The following is a description of a gene set: from publication Chen Y, Wang X (PMID 31504780) Human Gene Set: MIR6719_3P species: Homo sapiens Genes predicted to be targets of miRBase v22 microRNA hsa-miR-6719-3p in miRDB v6.0 with MirTarget v4 prediction scores > 80 (high confidence targets)., and this is the list of marker genes: BHLHE22, NAB1, SH3RF3, SULT1C4, MAP3K2, GRIA2, MRPS10, ANTXR2, NAMPT, VANGL1, MAP3K20, PPP2CA, SLC35A3, SELE, PAPOLB, NKRF, RICTOR, AFAP1L1, SCOC, SUSD6, RIF1, MGA, WDR7, SENP6, TMX4, ZNF75D, XPNPEP3, OTUD6B, TTK, MICU2, TBCEL, HOXC8, ARRB1, VTI1A, NR3C1, TTF1, GPR26, SLC19A2, ZNF286A, BRD3, ENPP5, WDR36, RTL8A, DENND4A, ERCC8, LINC02914, ZNF286B, ING2, FNIP1 (NCBI Gene Id 96459), NHS, DCLK3, CUL3, PSPH, MICAL2, ZNF268, SLC6A11, SLC12A3, CCDC88A, KDM6A, SOCS5, SEL1L, EPHA8, BICD2 (BICD cargo adaptor 2), C12orf75, KMT2E, SMARCAD1, GTF2A1, NLGN1, ANKS1B, ADGRG6, FAM204A, NR2C2, MBOAT1, TFRC, ATP6V0A2, FAM149A, NIPBL, CAMK2N1, USP20, XPNPEP1, PATL1, XRCC2, TRAF3, B3GALT6, RBFOX1, CNOT6L, COG5, SNX12, MMS19, SLC7A11, DEK, ACYP1, BMPR1A, TAF9B, TMEM263, GPBP1, RTKN2, NIBAN1, RSPO3, ZNF718 (zinc finger protein 718), TGFBR1, GABRB2, GMFB (NCBI Gene Id 2764), ATP5MC3 (ATP synthase membrane subunit c locus 3), ELF3, THSD7A, ANKRD26, KCNG3, ERGIC2, RTL8C, TET2, LRAT, OLR1, TASP1, ZCCHC7, EMB, TAF12, GSPT1, PPIL3, TEX2, TRPS1, TSC22D2